Given this list of marker genes SLCO1B1, ALAS1, UGT1A1, FECH, HMBS, COX15, PPOX, COX10, ABCG2, HMOX2, ALB (albumin), GSTA1, SLCO2B1, ABCC2, UROD, ALAD, UROS, ABCC1, CPOX, SLCO1B3, HMOX1, ALAS2, BLVRB, FABP1, FLVCR1, BLVRA, UGT1A4, here is a description of the gene set: Metabolism of porphyrins Human Gene Set: REACTOME_METABOLISM_OF_PORPHYRINS studied in species Homo sapiens